The following is a description of a gene set: Mouse Gene Set: GOBP_REGULATION_OF_MEIOTIC_NUCLEAR_DIVISION species: Mus musculus Any process that modulates the frequency, rate or extent of meiotic nuclear division, the process in which the nucleus of a diploid cell divides twice forming four haploid cells, one or more of which usually function as gametes., and this is the list of marker genes: Ooep, Eif4g3, Ube2b, Npr2, Wee2 (WEE1 homolog 2 (S. pombe)), Nanos2, Pde3a, Msx2, Npm2, Dazl, Fzr1 (fizzy and cell division cycle 20 related 1), Dmrt1, Camk2b (NCBI Gene Id 12323), Plcb1, Fbxo43, Gpr3, Rad1, Stra8, Psma8, Rad51ap1, Gja1, Lif, Zwint, Sirt2, Calr, Osm, Prdm9, Msx1, Wnt4, Fbxo5, Cdc20, Meiosin, Hormad1, Wnt5a, Rps6ka2, Piwil2, Trip13, Mos, Zfy2, Knl1